The following is a description of a gene set: studied in species Homo sapiens Joint contracture of the 4th finger Chronic loss of joint motion in the 4th finger due to structural changes in non-bony tissue. The term camptodactyly of the 4th finger is used if the distal and/or proximal interphalangeal joints are affected. Human Gene Set: HP_JOINT_CONTRACTURE_OF_THE_4TH_FINGER, and this is the list of marker genes: FBXW11, ASXL3, KDM5B, ERI1, TBX2, SIN3A, TLK2